The following is a description of a gene set: In the nucleus, NOTCH4 intracellular domain fragment (NICD4) binds transcription factors RBPJ (CSL) and mastermind family members (MAML1, MAML2 or MAML3) to form the NOTCH4 co-activator complex. The NOTCH4 coactivator complex stimulates transcription of well-established NOTCH targets HES1, HES5, HEY1 and HEY2 in a cellular context-dependent manner. NOTCH4 also stimulates transcription of the FLT4 (VEGFR3) gene, encoding vascular endothelial growth factor receptor-3 and ACTA2 gene, encoding smooth muscle alpha actin.<br><br>NICD4 inhibits TGF-beta-induced SMAD-mediated transcription via binding of NICD4 to TGF-beta activated SMAD3. part of: Signaling by NOTCH4 species: Homo sapiens Reactome Pathway: NOTCH4 Intracellular Domain Regulates Transcription, and this is the list of marker genes: HES1, MAML1, HES5, NOTCH4, EP300, KAT2B, NOTCH1, SNW1, ACTA2 (actin alpha 2, smooth muscle), HEY1, SMAD3, RBPJ, MAMLD1, FLT4, HEY2, MAML3, MAML2, KAT2A, NOTCH2, CREBBP